The following is a description of a gene set: species: Homo sapiens Human Gene Set: HP_ANTERIOR_SUBCAPSULAR_CATARACT A type of cataract affecting the anterior pole of lens immediately adjacent to ('beneath') the lens capsule. Anterior subcapsular cataract, and this is the list of marker genes: OPA3, PAX6, ATP7B, CHMP4B, WT1, FTL